Given this list of marker genes Grem1 (NCBI Gene Id 23892), Pth (NCBI Gene Id 57388), Rflna, Bmp2, Asxl2 (NCBI Gene Id 75302), Ltf, Rflnb, Actn3, here is a description of the gene set: studied in species Mus musculus Mouse Gene Set: GOBP_REGULATION_OF_BONE_MINERALIZATION_INVOLVED_IN_BONE_MATURATION Any process that modulates the frequency, rate or extent of bone mineralization involved in bone maturation.